The following is a description of a gene set: studied in species Homo sapiens Human Gene Set: HU_FETAL_RETINA_RGC Retinal Ganglion Cells from publication Hu Y, Wang X, Hu B, Mao Y, Chen Y, Yan L, Yong J, Dong J, Wei Y, Wang W, Wen L, Qiao J, Tang F (PMID 31269016), and this is the list of marker genes: SLIT1, UBE2D1, NICOL1, GRB2, DBN1, ATP5PO, ELAVL3, PPP2R1A, ARPP19, KIDINS220, SCG3, CD200, ATL1, RBPMS2, KLHL35, NRCAM, RUNDC3B, MEIS3, TLE4, CNTN2, FAR2, PRRT2, GFRA2, FXYD7, RAB3A, ATOH7, FAM171B (family with sequence similarity 171 member B), BNIP3, CELF4, NKAIN4, MIAT, GTF2A2, PPP1R14B, SEC61G (NCBI Gene Id 23480), CASP3 (NCBI Gene Id 836), CNRIP1, RXRG, CD24, DDAH2, DYNC1H1, RAB10, CACNA1B, NDUFS4, PLPPR1, TAF9, DLL3, SYT13, TUBB2B, DCTN2, TMSB15A, GABBR2, GDI1, PRDX5, COX6A1, PGAM1, MEAF6, RAB6A, FEZ1, TUBA1A, TPD52, SCG5, VKORC1 (vitamin K epoxide reductase complex subunit 1), GAPDH, OCIAD2, KIFAP3, TTC9B, CXADR, ITGB1BP1, IRX2, PPP1R1C, PFDN4, HMGCR, TSC22D1, FKBP3, AKR1C1, STX7, ARPC3, KPNA2, NDUFA12, TMEM14A, NAV1, SNCA (NCBI Gene Id 6622), TMOD2, NELL2, YWHAG, STX1A, UBE2L6, ACTR10, ZNF804A, NIPSNAP3A, LSS, SGCB, GLRX, RTN4, DACH1 (NCBI Gene Id 1602), SCD, ACSL4 (NCBI Gene Id 4426), EDIL3, SYT7, H3P6 (NCBI Gene Id 440926), AFAP1, PDE6D, PGK1, TRAPPC1, SH3BGRL2 (SH3 domain binding glutamate rich protein like 2), SMAD9, ROBO2 (NCBI Gene Id 90370), PGM2L1, NME1, FKBP1B, TOX2 (NCBI Gene Id 84969), NEFM, DCX, ETFB, GDAP1L1, ACHE, TCP1, CALM2, XPR1, MYL12B, PRPH, STARD3NL, TPPP3, MVD, AKAP6, NHLH2, PFDN2, MAPT, TFAP2D, RGS10, CTNNA2, DYNC1LI2, ELAVL4, TBCB, CDKN2D, ACOT7, MAP4, OLFM1, CBLN2, SRI, TCEAL7, TUBB, RAB2A, FIBP, TMSB4X, KLHDC8A, RNF5, BEX1, PRMT2, L1CAM, FABP3, ZC2HC1A, STXBP1, POLR2K (RNA polymerase II, I and III subunit K), CCDC112 (coiled-coil domain containing 112), PAFAH1B3, MAPRE2, LNPK, BNIP3L, FGF13, SEC11C, UCHL1, ATAT1, IRX3, ISL1, PRUNE2, DNER, KIF3C, CEND1, TMEM59L, SEZ6L2, CYCS, PBX3, EBP, SLC38A1, DSTN, PKIA, ZMIZ1, CPNE4, ACAT2, BLOC1S2, FAM241B, SOX11, PCSK1N, DBNDD1, NKAIN1, CDC42 (cell division cycle 42), MAP1LC3B, H3P16, SLC2A6, CACNB3 (NCBI Gene Id 784), CXCR4, RAP1GDS1, CHRNA3, CALM3, FDPS, TAC1, FSD1, FHL1, APLP1, TAGLN3, RIT2, ALDOC, GPI, ARL6IP5, KCTD16, DCTN3, LCOR, VDAC3, FYN, SCN9A, SCN3A, DACH2, SQLE, COMTD1, NMNAT2, SH3BGRL3, PFKFB3, GET1, YWHAH (NCBI Gene Id 7533), COX17, NLN, RAB31, EBF3, APBB2, RAB3B, RUFY3, ELAVL2, AP3S1, MAGED4B, RAB33A, PCMT1, GDAP1, RUFY2, CNR1, POU4F2, EIF1B, PNMA2, ATP6V1G2, GNAO1, VAT1, TUBB2A, HEY1, BTBD10, KIF5A, RBFOX2, ACSL3, RBX1, OPTN, KIF5C, CETN2, SVBP, STMN3, RAB6B, DBI, CRIP2, REEP1, LRRN3, DYNC1I2, CHGB, RGMB, SRP9, SYT5, CCT5 (chaperonin containing TCP1 subunit 5), NDRG4, PPP1R1A, CPNE9, SBK1, MAP2, ACTL6B (NCBI Gene Id 51412), TP53I11, SCOC, TMSB4XP4, DCC, DPYSL2, RBPMS, VPS72, NTRK1, ADAM11 (NCBI Gene Id 4185), HMGCS1, FNDC5, CRABP1, STMN4, FXYD6, AKR1C2, KLF7, DPYSL3, NCAN, DYNC1LI1, NCAM1, CCDC184, SLC35F1, CDS2, DPYSL5, PSENEN, VSTM2L, TMEM35A, FAM229B, TMEFF2, SNCG, MORF4L2, TMEM97, PLXNA3, NAV2, MSMO1, VDAC2, INSIG1, ZCCHC17, WASF1, TMEM50A, NPDC1, DCDC1, ARPC1A, JPT1, EPHA5, MAP1B, TMSB10, CRMP1, SNAP25, TPM3, NEFL, DTD1, GNG2, UBE2E2, ACLY, CORO2A, SMS, EPHB1, ENO2, ALCAM, RTN3, MLLT11, CRABP2, KLHL1, ADD2, RUSC1 (NCBI Gene Id 23623), KLC1, DPYSL4, RND3, LDHA, CRNDE, CPLX2, RTL8C, EPS8L1, BASP1, DYNLT3, STMN1, ADCY1, ADGRG1, MFSD10, RCN1, DYNLRB1, CHRNB3, GAP43, NOP10, DYNLT1, ARPC5, SEZ6L, KIF3A, MYO1B, NRN1, RBFOX3, ATP5MK, YWHAZ, LDOC1, NAGK, RABAC1, TBPL1, PNMA1 (NCBI Gene Id 9240), CALB2, CEP170, ATCAY, TXNDC17, TRIM36, PCSK2 (proprotein convertase subtilisin/kexin type 2), GABARAPL2, VBP1, JUP, SLC17A6, TXN, GNAI1, FABP5, GRIA2, SST, BMERB1, ATP6V1H, CHN1, NDUFB8, FASN, MYCN, ACTR1A, FAM162A, GSTA4, TSPAN7, YWHAQ, PDK1, C14orf132, FAXC, IDH1, ANK2, LRFN5, ARL3, IDI1, SEMA6A, HSPA12A, ISLR2, RALYL, NOVA2, PAPSS1, SRGAP1, EBF1, MTCH2, MGST3, JAKMIP2, MAP6, MAPK10, PPIAP22, TENM3, STMN2, HCFC1R1, WDR47, NSG1, DCLK1, HDAC2, PPP2R2B, BEND5, PAK5, SYT1, CADM1, ADISSP, CEP15, FDFT1, PHACTR3, PHYHIPL, S100A10, SYT4, FABP5P7, RALGDS, FNBP1L, POU6F2, SMIM18, RTN1, INA